The following is a description of a gene set: Catalysis of the reaction: a secondary alcohol + NADP+ = a ketone + H+ + NADPH. species: Mus musculus Mouse Gene Set: GOMF_CARBONYL_REDUCTASE_NADPH_ACTIVITY, and this is the list of marker genes: Cbr2, Dhrs2, Dcxr, Dhrs7, Cbr3, Dhrs7l, Cbr1, Cbr1b, Dhrs1 (dehydrogenase/reductase 1), Dhrs4 (NCBI Gene Id 28200), Kcnab1